Given this list of marker genes STX7, MR1, NECTIN2, HLA-A (major histocompatibility complex, class I, A), FCGR2B, RAET1E, RAET1L, IL12B, IL23R, HLA-DRB1, CD1E, HLA-F, PTPRC, LILRB1, B2M, CD1C, HLA-DRA, HLA-H, IL12RB1, CD1B, RIPK3, IL7R, PPP3CB, CEACAM1, CD1D, ULBP3, RAET1G, TAP2, FADD, ULBP1, AGER, CD1A, KLRC1, IL23A, HLA-E, CYRIB, AZGP1, KLRD1 (NCBI Gene Id 92677), ULBP2, XCL1, PVR, NCKAP1L, P2RX7, HLA-G, HLA-C, SLC22A13, IL12A, HLA-B, here is a description of the gene set: Any process that modulates the frequency, rate, or extent of T cell mediated cytotoxicity. Human Gene Set: GOBP_REGULATION_OF_T_CELL_MEDIATED_CYTOTOXICITY species: Homo sapiens